The following is a description of a gene set: from publication Newell KA, Asare A, Kirk AD, Gisler TD, Bourcier K, Suthanthiran M, Burlingham WJ, Marks WH, Sanz I, Lechler RI, Hernandez-Fuentes MP, Turka LA, Seyfert-Margolis VL, Immune Tolerance Network ST507 Study Group (PMID 20501946) studied in species Homo sapiens Genes down-regulated in periperal blood monocytes (PBMC) from kidney transplant recipients: tolerant versus immunosuppressive therapy. In this study, investigators recruited the largest reported cohort of tolerant kidney transplant recipients who maintained their graft after ceasing to take their immunosuppression drug, and compared this cohort to subjects with stable allograft function while on immunosuppression and healthy non transplated, controls. Using gene expression studies, they identified genetic markers that are strong candidates for predicting kidney transplant candidates who may benefit from minimization or withdrawl of immunosuppression. Microarrays were used to detect expressed gene profiles of whole-blood total RNA from subjects in the tolerant, standard immunotherapy and healthy control participants Human Gene Set: GSE22229_UNTREATED_VS_IMMUNOSUPP_THERAPY_RENAL_TRANSPLANT_PATIENT_PBMC_DN, and this is the list of marker genes: TMBIM1, LETMD1, BCORL1 (BCL6 corepressor like 1), SMOX, IFTAP, SPMIP4, DYNLT3, ANXA9, PAM, DACH1, FCER1A, EFCAB14, INAFM1, MEAK7, ECHDC3, TTC8, NKX2-3, DTX3, OCIAD2, TRIM47 (tripartite motif containing 47), CPT2, IGBP1, CBX7, NPL, TMEM176A, NECTIN4, SELENBP1, COL4A2, CSNK1E, ENO2, PKN3, MYC, PALLD, TLE6, RBP1, ITGB3, CLN3, DUSP1, LHCGR, INHA, PARM1, SHANK3, DECR1, OPTN, PPP1R26, FNBP1, IRF9, CTSW, IGDCC4, P2RY14, MIDEAS, SLC25A45, LHFPL2, HLA-E, TMEM41A, SLFN13, TAL1, TNS1, SQOR, FOSL2, MS4A6A, EMILIN1, SLC7A4, RGS9BP, ZNF235, RNF217, PRKG1, HLA-DMA, VKORC1, APPL2, STX3 (syntaxin 3), IL11RA (NCBI Gene Id 3590), RASGEF1B, SYNE1, MANSC1, SPTA1, ACER2, METTL21A, ABCA7 (NCBI Gene Id 82843), LDHB, ABCA2, MANBA, GSTK1, TNNI3, CRTAP, LYPD6B, SUCLG2, SAMHD1, C3orf33, ZYX, ABCC4, RNF213, NOPCHAP1, LRMDA, BTNL9, GRB10, MED22, ABCC1, MBLAC2, FAM168A, FMO5, MACROD1, GDF3, ST6GALNAC5, PBX3, DDHD2, CHST11, IFFO2, CDK14, FBP1, EVA1B, RAB17, GAA, NEFH, ZNF467 (zinc finger protein 467), RPAP2, CASP12 (NCBI Gene Id 120329), FRRS1, NTPCR, PRDX6, SLC35D2, C15orf61, JSRP1, RAP2A, NDN, PADI4, PTER, DMWD, FHL1, RRAD, CLNK, NLGN2, ZBTB45, FAM110B, SLC39A11, ACAP1, UNC13D, ANGPT1, SFI1, ITSN1, RAB4A, GKAP1, POGLUT3, MYCT1, IKBKE, STARD10, IFI44, ARSK, NOS1AP (NCBI Gene Id 9722), FGF11, GHR, NEXN, AIFM2, TTC12, SERPINB9, SUOX, RINL, AVPI1, TNFRSF1A, OSBPL1A, COL4A1, CA9, TBC1D24, BSCL2, PEAR1, RAB31, PDZK1IP1, SKI, ALDH1L1, NPR2, KDM5B, TRAF1, ITGA2B, ATP6V0E1, MKRN1, XAF1, BORCS6, FGD3, CAVIN2, EXT2, INTS6L, PIGP, SOAT2, TMEM8B, ARAP3, SLC14A1, CHMP4B, SLC66A2, SNX18, NFIC, CSAD, CALML4, LIPT2, SORT1, MYLK3, SPINT2, REC8, SNX24, WDFY1